The following is a description of a gene set: studied in species Homo sapiens Reactome Pathway: Acyl chain remodelling of PS In the acyl chain remodelling pathway (Lands cycle), phosphatidylserine (PS) is hydrolysed by phopholipases and subsequently reacylated by acyltransferases. These cycles modify the fatty acid composition of glycerophospholipids to generate diverse molecules asymmetrically distributed in the cell membrane. part of: Glycerophospholipid biosynthesis, and this is the list of marker genes: PLA2G4B, PLA2G4E, PLA2G4D, MBOAT1, OSBPL10, PLA2G1B, OSBPL8, PLA2G2F, LPCAT3, OSBPL5, PLAAT3, PLA2G5, PLA2G4F, PLA2R1, PLA2G2E, PLA2G10, PLA1A, PLA2G12A, PLA2G4A, PLA2G2A, PLA2G2D, LPCAT4